Given this list of marker genes F3, CD177, SERPINE2, F12, TFPI, FGA, SERPINA5, F10, PROC, SERPIND1, A2M, PROCR, FGG, PROS1, GP5, SERPINC1, VWF, F5, PRTN3, C1QBP, F8, SERPING1, F7, KLKB1, F2, THBD, F2R, PRCP, F11, F13A1, PF4V1, GP1BB, F13B (NCBI Gene Id 2165), F9, KNG1, PF4 (NCBI Gene Id 5196), FGB, GP1BA, GP9, here is a description of the gene set: Formation of Fibrin Clot (Clotting Cascade) studied in species Homo sapiens Human Gene Set: REACTOME_FORMATION_OF_FIBRIN_CLOT_CLOTTING_CASCADE